Given this list of marker genes GNAT1, PDE6G, CNGB1, PPEF1, RGS9, NMT1, GUCA1C, RHO, CALM1, PDE6B, GUCA1B, METAP1, SLC24A1, GNGT1, GUCY2F, RCVRN, SAG, GUCY2D, CNGA1 (NCBI Gene Id 1259), GUCA1A, GNB5, FNTA, RGS9BP, METAP2, GNB1, CAMKMT, GRK7, GRK1, PRKCA, PRKCQ, NMT2, PDE6A, FNTB, GRK4, here is a description of the gene set: The visual pigment (rhodopsin in rods) consists of an 11-cis-retinal (11cRAL) chromophore covalently attached to a GPCR opsin family member via a Schiff base linkage. Upon photon absorption, 11cRAL isomerizes to all trans retinal (atRAL), changing the conformation of opsin to a form that can activate the regulatory G protein transducin (Gt). The alpha subunit of Gt activates phosphodiesterase which hydrolyses cGMP to 5'-GMP. A high level of cGMP keeps cGMP-gated cation channels open, so lower cGMP levels close these channels and hyperpolarize the cell. The hyperpolarization spreads passively to the synapse located at the opposite end of the rod, where it subsequently closes voltage-gated calcium channels. Vesicular release of the neurotransmitter glutamate subsides as the intracellular calcium levels drop. This diminution of neurotransmitter release relays the light signal to postsynaptic neurons. The events below describe activation, inactivation, recovery and regulation of the phototransduction cascade in rods (Burns & Pugh 2010, Korenbrot 2012, Smith 2010). species: Homo sapiens Reactome Pathway: The phototransduction cascade part of: Visual phototransduction